The following is a description of a gene set: Neighborhood of CDC2 Neighborhood of CDC2 cell division cycle 2, G1 to S and G2 to M in the GNF2 expression compendium Human Gene Set: GNF2_CDC2 studied in species Homo sapiens, and this is the list of marker genes: TMPO, ASPM, CCNA2, RRM2, CDCA3, SMC4, TYMS (NCBI Gene Id 7298), KIF20A, MT1JP, NCAPG, PRC1, ZWINT, RFC4, BIRC5, PRIM1, CDC20, ASF1A, HJURP, NUSAP1 (NCBI Gene Id 82534), GINS2, DLGAP5 (DLG associated protein 5), UBE2C, CENPF, HMMR, KIF15, RFC3, H2AX, TPX2, MCM2, NDC80, HMGB2, UBE2S, PTTG1, CDCA8, MELK, SMC2, SHCBP1, PCNA, PLK4, RRM1, CDK1, DNAJC9, AURKA, CKS2, MKI67 (marker of proliferation Ki-67, NCBI Gene Id 4288), TOP2A, FANCI, CENPE, CCNB2, MYBL2, FOXM1, CCNF, KIF4A, KIF18B, CKAP2, NSD2, EZH2, TTK, FEN1, E2F8, KIFC1, KIF11